Given this list of marker genes Gsto1, Akap6, Cx3cl1, Il13, P2ry6, Calm1, Capn3, Pkd2, Gpr39, Ntsr1, Plcg1, Jph2, Cemip, Cxcr3, Calm2, Thy1, Aplnr, Sri, Calm3, Bdkrb1, Htt, Gper1, Xcl1, Clec4b1, Bax, Pdpk1, Hap1, Dbi, Cxcl9, Gstm7, Trpc1, Cd19, Lhcgr, Trdn, F2rl3, Casq1, Ednra, F2, Drd1, F2r (coagulation factor II thrombin receptor), Npsr1, Snca (NCBI Gene Id 20617), Cxcl11, Cxcl10, Abl1, here is a description of the gene set: Mouse Gene Set: GOBP_POSITIVE_REGULATION_OF_RELEASE_OF_SEQUESTERED_CALCIUM_ION_INTO_CYTOSOL species: Mus musculus Any process that activates or increases the frequency, rate or extent of the release into the cytosolic compartment of calcium ions sequestered in the endoplasmic reticulum or mitochondria.